Given this list of marker genes ATP5F1E, ATP6V1E1, COX7B, ATP2C1, COX5A, NDUFS6, SLC25A5 (solute carrier family 25 member 5), COX17, NDUFB5, UQCRFS1, ABCF1, NDUFC1, ATP5PO, ATP6V0D1, COX7C (NCBI Gene Id 1350), ATP5F1A, NDUFB1, SLC25A4, ATP5MC2, COX8A, SLC39A6, NDUFA7, TOMM20, ATP6V0C, COX6A1, ATP6V1B2, NDUFA4, MAOB, ATP6V1G1, ATP5F1D, PPA1, CYC1 (NCBI Gene Id 1537), SDHB, SDHC, UQCR11, NDUFAB1, NDUFA2, NDUFS4, COX5B, NDUFA1, UQCRB (ubiquinol-cytochrome c reductase binding protein), NDUFA9, ATP6V1D, COX11, NDUFS8, ATP5MF, NDUFS2, ATP5F1C, NDUFS3, ATP5F1B, SDHA, UQCRQ, NDUFA5, COX7A1, ATP6AP1, ATP5PF, NDUFB10, UQCRC1, SDHD, NDUFV1, ATP6V1H, COX7A2, ATP5MC1, SURF1, SLC9A6, ATP5ME, NDUFV2, SLC25A3, NDUFA6, NDUFB7, UCP1, ATP5PD, UQCRC2, ATP6V0B, ATP6V0E1, ATP6V1F, ATP6V0A1, ATP5MC3 (ATP synthase membrane subunit c locus 3), CYCS (cytochrome c, somatic), UQCRH, COX4I1, NDUFB3, NDUFB6, NDUFA3, COX6B1, TIMM17B, NDUFB8, COX6C, NDUFS5, here is a description of the gene set: Genes in the cancer module 62. species: Homo sapiens Human Gene Set: MODULE_62